The following is a description of a gene set: from publication Cao J, O'Day DR, Pliner HA, Kingsley PD, Deng M, Daza RM, Zager MA, Aldinger KA, Blecher-Gonen R, Zhang F, Spielmann M, Palis J, Doherty D, Steemers FJ, Glass IA, Trapnell C, Shendure J (PMID 33184181) studied in species Homo sapiens Marker genes curated from the annotated cluster as represented in the Descartes Human Gene Expression During Development database. The gene expression program underlying the specification of human cell types is of fundamental interest. The study authors generated human cell atlases of gene expression and chromatin accessibility in fetal tissues. For gene expression, the study authors applied three-level combinatorial indexing to >110 samples representing 15 organs, ultimately profiling ~4 million single cells. The study authors leveraged the literature and other atlases to identify and annotate hundreds of cell types and subtypes, both within and across tissues. Our analyses focused on organ-specific specializations of broadly distributed cell types (such as blood, endothelial, and epithelial), sites of fetal erythropoiesis (which notably included the adrenal gland), and integration with mouse developmental atlases (such as conserved specification of blood cells). These data represent a rich resource for the exploration of in vivo human gene expression in diverse tissues and cell types. Human Gene Set: DESCARTES_FETAL_CEREBELLUM_INHIBITORY_INTERNEURONS, and this is the list of marker genes: C1QL3, NNMT, VCAN-AS1, NEUROG2, PAX2, GOLGA6L2, SPOCK1, ENSG00000228021, SLC6A5, RN7SL803P, KIT, ENSG00000253857, ENSG00000226939, ROBO3, ENSG00000225420, ALKAL2, ENSG00000233968, LINC02477 (long intergenic non-protein coding RNA 2477), LINC02873, LARGE2, PRR35, NPY2R, IGFBP5, LINC00587, SLC35F4, TFAP2A-AS1, FNDC1, LBX1, LINC02502, LRRC38, INHBA, CACNG3, SLC30A3, CPLX4, NXPH2, KRT222, LINC01320, LINC02408, LBX1-AS1, CCBE1, FNDC1-IT1, TFAP2B